The following is a description of a gene set: A process in which force is generated within smooth muscle tissue, resulting in a change in muscle geometry. This process occurs in the uterus. Force generation involves a chemo-mechanical energy conversion step that is carried out by the actin/myosin complex activity, which generates force through ATP hydrolysis. The uterus is a muscular organ of the female mammal for containing and usually for nourishing the young during development prior to birth. Mouse Gene Set: GOBP_UTERINE_SMOOTH_MUSCLE_CONTRACTION species: Mus musculus, and this is the list of marker genes: Abat, Tacr2, Oxt, Adra2c, Agt, Setd3, Adra2a, Oxtr, Tacr3, Lck, Tacr1, Adra2b, Gper1